Given this list of marker genes HDAC1, SS18, ACTB, H2BC9, ARID1B, ZNF454, ZNF273, H2BC5, H2BC15, CBX5, H2AC7, RBBP4, H2BC21, H2BC13, CHD3, DPF2, DNMT3L, ZNF354A, ZNF816, H3-3A, H2AZ2, ZNF136, UBE2I, SS18L1, ZNF534, ZNF765, SETDB1, ZNF30, ZNF331, SMARCD3, ZCCHC8, SMARCE1, CHD4, ZNF320, H2BC17 (NCBI Gene Id 8348), SMARCD2, H4C1, MTREX, TASOR, ZNF425, H2AC20, DNMT3A, MTA1, SMARCA4, ATF7IP, ARID1A, ACTL6A, ZNF28, GATAD2B, RBM7, HDAC2, MORC2, H2BC12, EHMT2, ZNF224, H2BC14, MTA3, ZNF418, RBBP7, EHMT1, SMARCD1, H3C15, ZNF382, BCL7A, BCL7C, H2AC14, ZNF257, H2BC11, H2BC12L, H2BC26, ZNF519, DPF1, MBD3, BCL7B, H2AX, MTA2, H2AC4, ZNF669, ZNF317, H2BC3, DPF3, ZNF680, H2BC1, ZNF324, SUMO2, ZNF610, SMARCA2, ZNF141, SMARCC2, H2AC6, H2AB1, PPHLN1, H2BC4, ZNF778, ZNF33A (zinc finger protein 33A), TRIM28, ZNF264, SPOCD1, ZNF547, H2AJ, H2AC18, SMARCB1, MPHOSPH8, ZNF93 (zinc finger protein 93), GATAD2A, C19orf84, ZNF649, PIWIL4, SMARCC1, ZNF708, H3C1, here is a description of the gene set: part of: Epigenetic regulation of gene expression Reactome Pathway: Regulation of endogenous retroelements studied in species Homo sapiens Transposable elements (TEs) constitute about 48.34% of the human genome and can be classified by their transposition mechanisms: DNA transposons (about 3% of the human genome) transpose by excising a DNA intermediate and inserting it into a new location; retrotransposons (about 33% of the human genome) transpose by transcribing an element, reverse transcribing the RNA to DNA, and inserting the DNA copy into a new location.<br>Retrotransposons can be divided into those that contain long terminal repeats (LTRs) and those that lack LTRs. Retrotransposons that contain LTRs are believed to be remnants of retroviruses, are therefore called endogenous retroviruses, and constitute about 9.45% of the human genome. No endogenous retroviruses are known to be currently transpositionally active in humans, with the most recent transpositions estimated to have occurred about 0.67 million years ago.<br>Retrotransposons that lack LTRs constitute about 34% of the human genome and mostly have uncertain origins: Long interspersed nuclear elements (LINEs, about 18,99% of the genome) encode two proteins, an RNA-binding protein (ORF1p) and a reverse transcriptase/endonuclease (ORF2p), that confer autonomous transposition activity; short interspersed nuclear elements (SINEs, about 14.66% of the genome) do not encode proteins and require proteins produced in trans by LINEs for transposition. Of the 3 families of LINEs, only the LINE1 family is known to be currently active. Of the SINEs, only Alu elements, which evolved from the 7SL RNA of the signal recognition particle, are known to be currently active.<br>Surprisingly, although retroelements can cause deleterious mutations due to insertions and recombination, their genomic elements and expression are required for embryogenesis. The envelope proteins ERVW-1 (Syncytin-1) of the HERV-W endogenous retrovirus and ERVFRD-1 (Syncytin-2) of the HERV-FRD endogenous retrovirus act to fuse cells in the trophoblast. TEs contain binding sites for pluripotency factors (for example OCT4, SOX2, and NANOG) as well as cell lineage-specific factors, In humans, a hominid-specific TE family, LTR5Hs, become transcriptionally active during specification of primordial germ cells (PGCs) and serve to bind PGC transcription factors. In mice, the retroviral MERVL element is transcribed in cleavage-stage embryos and during this time MERVL regulatory DNA elements activate expression of more than one hundred genes involved in zygotic genome activation. In mouse embryos, transcripts from LINE1 retroelements are required to exit the 2-cell stage by serving as scaffolds for Nucleolin (NCL) and TRIM28 (KAP1) to repress Dux expression and activate rRNA expression. LINE1 elements are also active in expressing cell type-specific transcripts in the developing and adult human brain. By binding transcription activators, retroelements such as LTR5 and LTR7 can also act as cis-regulatory networks in somatic cells.<br>Retroelements are generally silenced transcriptionally by DNA methylation and histone modifications or post-transcriptionally by RNA interference, however repressive chromatin marks are lost and retroelements are transcribed at two points during mammalian development: in early germ cells prior to meiosis and in zygotes immediately after fertilization. In germ cells, small RNAs of 24-31 nucleotides known as PIWI-interacting RNAs (piRNAs) are generated from transcripts of retroelements and, when bound to PIWI proteins, guide post-transcriptional decay of retroelement transcripts and re-impose chromatin modifications that repress transcription of retroelements.<br>Endogenous retroelements are also transcriptionally silenced by zinc finger-containing proteins, KRAB-ZFPs, that bind specific DNA sequences. The human genome contains 423 KRAB-ZFP genes that encode 742 KRAB-ZFP proteins that appear to evolve in response to invasion by retroelements. Specific KRAB-ZFPs bind specific families of retroelements and recruit the TRIM28 scaffold protein (also known as KAP1), which assembles a complex containing the histone methylase SETDB1 and the NuRD repressor complex to silence transcription of the retroelements.<br>The Human Silencing Hub (HUSH) complex directly binds RNA of LINE1 elements and trimethylates lysine-9 of histone H3 (H3K9) of nucleosomes assembled on the LINE1 that produced the RNA. Trimethyl H3K9 (H3K9me3) is a repressive mark thus the result is de novo formation of heterochromatin at LINE1 elements. The HUSH complex also binds H3K9me3 and trimethylates H3K9 of adjacent nucleosomes, resulting in propagation of heterochromatin.<br>In mice, N6 methylation of adenosine residues in RNAs can cause destabilization of the RNA and transcriptional silencing of the locus that produced the RNA. The effect of N6-methyladenosine on expression of human retroelements is less clear. Xiong et al. (2021) observed that N6-methyladenosine in transcripts of young LINE1 elements increased RNA expression while N6-methyladenosine in transcripts of ancient LINE1 elements decreased RNA expression. The mechanism responsible for the difference may involve the promotion of translation of young LINE1 elements by N6-methyladenosine residues located in the 5' untranslated region.